Given this list of marker genes ADAMTS15, GLA, GALC, COMP, LMX1B, SPTLC2, HEXB, PMP22, PRNP, SLC26A2, here is a description of the gene set: studied in species Homo sapiens A type of paresthesia (tingling, pins-and-needles, burning or numbness or stiffness) that occurs in the hands and feet and particularly in the fingers and toes. Human Gene Set: HP_ACROPARESTHESIA Acroparesthesia